Given this list of marker genes WRNIP1, SCAP, TST, CYB561, PCLO, SLC38A10, BEX2, CACNB3, NAAA, EML3, MAGI1, EFEMP1, ZC3HAV1, TVP23A, SLC25A4, SYT17, FBXW9, ANKRD13B, FUCA1, EPS8 (EGFR pathway substrate 8, signaling adaptor), DVL3, CD55, EXOSC4, SPR, TOM1L1, HSD17B14, DNAH14, KRT5 (NCBI Gene Id 3852), TM7SF3, AP5Z1, STRADB, PACRG, CHCHD6, DNALI1, CCDC85C, UBTD1, P4HTM, GRB7, ADARB1, SLC51A, MTHFR (NCBI Gene Id 4524), CAV2, STX11, IFT140, C1RL, SMOC2, TLL1, P4HA2, IGFBP2, FIG4, MTUS1, NOP16, HVCN1, FRAS1, NPDC1, C4B, P3H2, RALGDS, UBE3C, PAK4, TYRO3, HINT3, FXYD7, JOSD1, ITGA6, LTBP2, PDZD2, GATA6-AS1, FMO1, PDE7B, RBP7, TSPAN13, PLAAT4, PCOLCE2, ADAMTSL4, DECR2, SLC2A1, GAS6, LYST, NACC2, TNNI3 (troponin I3, cardiac type), SLC25A23, PTPRF, NPW, ERO1B, NAT8L, JMJD8, TSC1, DISP1, LRATD2, VPS18, SIRPA, PHLPP2, IL13RA1, ANK3, TMEM8B, ADIRF, CACNA2D3, TRADD, HSBP1L1, NSUN7, SLC7A7, IL10RB, NHERF4, NADSYN1, PROS1, TNIP2, CACNA1H, WWC2, CRLS1, RECK, THBD, SLC4A2, RASSF7 (Ras association domain family member 7), SRP19, CCDC106, CDK2AP2, OSTM1, ADAMTS8, ZNF503-AS2, PIM3, PSMB8, PLXNB1, VAMP8, CCDC51, GSDMD, TMEM151A, IFI35, SPEG, FLRT3, TMEM88, SPTLC2, ANXA3, IRAK1BP1, SPECC1, ZNF174, HSPA12A, PALS1, C11orf98, HOOK1, PDGFD, CRB2, COLGALT2, IL17RD, HRH2, NELL2, RHPN2, SPACA6, ITGB8, ITM2A, HEXB, HDAC7, PLA2G2A, CCDC112, TOLLIP, SYCE1L, EPS8L1, SLC16A4, UCHL1, DTD2, SPMIP5, LGALS2, COL2A1, METTL21A, CTIF (cap binding complex dependent translation initiation factor), TSPAN7, RNF207, ACKR3, SLC39A10, IL1R1, STK26, FABP3, UBXN2B, MKNK2, TGFB3, PAWR, ITGB5, THBS3, DPP4, SLC26A11, FAM50B, DOK4, PEG3, SNX8, FCGR2A, RTN4R, SGSH, ECHDC2, USP9X, AMOTL2, SLC16A1, WARS1, LRRC8A, SCPEP1, CCN4, LINC02381, TEAD4 (TEA domain transcription factor 4), EMP1, SEZ6L2, PYCARD, NBPF9, SINHCAF, SBSPON, TLCD4, DHCR24, TM4SF1, COL9A2 (collagen type IX alpha 2 chain), SGPL1, TFPI2, ITLN1, ABHD12B, PRKCI (protein kinase C iota), ZNF579, PDGFC, MYO1C, NBPF26, ABHD5, ZDHHC24, MID1, CDON, ALDH1A3, SLC25A29, INF2, TSPAN18, SH3GLB2, PGF, UNC5B-AS1, FGF13, CDC42EP3, BCAS4, PKHD1L1, GJA1, CFC1, COL26A1, DCTN6, BICDL1, SERPINB1, KLHL36, FGF18, NEO1, TNNI1, TNFAIP8L3, MUS81, ATP9A, NLRX1, CCDC74B, ERBIN (NCBI Gene Id 55914), SMAD3, PHYHD1, ARRDC1, MIF4GD, LLPH (NCBI Gene Id 84298), CTSH, INTS5, ACTC1, CGNL1, HHIP-AS1, HPGD, DYNLT2B, BTBD6, BMP3, UNC5B, MN1, MMEL1, ARL2, PRSS33 (NCBI Gene Id 260429), TAF10, LINC00842, BST1, LRRN4, ASPHD1, PKP2, BDNF, ARRDC4, TGM1, NDRG1, FRY, ADAMTS5, ZFPM2, EEIG1, PTPRQ, SMPD3, IGFBP6, PLEC, C3, ACOT7, TRNP1, SP1, ALCAM (NCBI Gene Id 214), GKAP1, NQO1, LINC01550, ROM1, TPD52, MTHFS, NGEF, PITPNC1, RHOD, FAM98A, ZNF219, WFDC1, CNTN3, SLC22A18, LPCAT3, EPHA3, ARMC9, STAU2, PEX11A, GSG1L, MGAT4B, SORBS2, NRBP2, ITPR3, MAP3K3, SIRT5, BCR, SH3BP5 (SH3 domain binding protein 5), TGFB2, ERRFI1, EPB42, MAILR, AAGAB, TBC1D22A, AGAP3, KLK8, FAAH, ABHD8, GLS, LGALS8, DIPK1A, TBX18, BTC, HEG1, FSTL3 (follistatin like 3), SYS1, STK24, EGLN2, CARNS1, PARP9, JUP, PODXL, PRELID2, NDUFA7, MRGPRF, PKIA, PTDSS2, DDR1, EPS8L2, MTHFD2L (methylenetetrahydrofolate dehydrogenase (NADP+ dependent) 2 like), ARPC1B, CITED4, REPIN1, GCLC, SEMA6A, SERGEF, PHYHIP, ANKRD50, ADAMTS3, FZD7, PLLP, TMEM176B, COL9A3, TRAF5, BEX1, REC8 (REC8 meiotic recombination protein), NUDT14, CTTNBP2NL, SETDB2, BICC1, B3GALNT1 (beta-1,3-N-acetylgalactosaminyltransferase 1 (Globoside blood group)), CDV3, CLIC3, SVIL, RGS5, NIPAL3, FKBP11, GRID2, RNF141, FAM174C, EDN3, MYCBP, CRABP2, HOXC5 (NCBI Gene Id 3222), NXPH2, TENM2 (teneurin transmembrane protein 2), DNAJC22, ASAP3, PTPRE, CADM2, PPP1R21, HHIP, KRT19, CCDC74A, PERP, HSPG2 (NCBI Gene Id 7796), RAP1GAP, ZMIZ1, NRG4, PGRMC2, NFATC2, NMU, PTPN14, ADAMTS9, COL8A1, MVP, ITPK1 (inositol-tetrakisphosphate 1-kinase), ASH2L, STIM2, ZMYM3, IL6R, NET1, INO80C, GALNT18, CADPS2, TCEA3, OTUD5, BCL3, GABARAPL1, SOX6, FLRT2, KHDRBS3, SSX2IP (NCBI Gene Id 22892), DAG1, CFI, DUSP2 (dual specificity phosphatase 2), TKFC, SLC38A1, GPR137B, TOMM34, LIMS2, LRRC32, SVIP, PYGL (glycogen phosphorylase L), CTXN1, MAMSTR, SMIM11, C21orf91, ABHD17A, ANXA8, RPRD1B, LINC00665, AGRN, SNAP47, TAOK2, RAB33A, ADAM17, EHD4, ATP11A (NCBI Gene Id 84170), EPCIP, CYTOR, CDK7, SYNGR2, PCDHAC2, CEP162, TOR1AIP2, OCIAD2, PLXNA2, PODN, SASH1, EFNB3, PLEKHA4, PNMA8A, TCEAL2, ARL8A, NOL4L, ETHE1, CLPTM1L, CDH3, ARHGAP22, AQP3, CDH2, MANSC1, AXL, PLAUR, ST6GAL1, WFDC2, KIF13A, AMPD2, TMUB1, ATF7IP2, SLC6A13, LPAR5, DHRS3, ANOS1, NDFIP2, ARSA, RSPO1, AMHR2, SLC29A3, GALNT9, MAP3K8, CERK, SLPI, HTR2B, CXADR, EPHA7, DLG2, DNAJB12, SLITRK4, MST1, PHC2, WT1, COL11A1, ANXA8L1, MLLT1, CLDN15, DSC2, FNDC1 (NCBI Gene Id 84624), LINC01018, CFC1B, RSPO3, RCHY1, FN3K, C1QTNF1, TNFRSF12A, SLC10A3, TTLL5, NPNT, COBLL1, CMYA5, TAP1, GLP2R, ITGA3, RAB7B, FOXP4, TDRP, RAB6B, GBP3, NMI, PDGFA, PLCB1, KRT8, TMCO3, TBC1D9, LRRTM1, LINC01133, TES, CCDC186, CRIM1, PPIL6, PSMB9, AGFG1, ZNF512B, PDXK, CALHM6, GSDME, STRBP, GADL1, FBN3, HACD1, ELFN1, FDXR, ARHGAP23, GRM7, SH2D4A, TCAIM, DPP3, NSG1, PHACTR1, OSMR (NCBI Gene Id 9180), TOB1, PLCE1, DOCK11, KRT17 (keratin 17), MINCR, MOK, NEDD4L, MET, ADAM33 (NCBI Gene Id 80382), NINJ1, CFB, UBE2Q1, CYP4B1, TOX, NHSL1, CA9, PPL, CFAP68, RERG, SMTNL2, FCHO1, KDELR3, OLFML2B, SLCO3A1, MCUB (mitochondrial calcium uniporter dominant negative subunit beta), RFK, CCPG1, EFNB2, RIC3, NHSL3, KIRREL1, NCOA7, OSCP1, CD47, LSR, LMO7, EGFLAM, ERAP2, CYSTM1, MT1E, NAV2, IQCA1 (NCBI Gene Id 79781), SH3BP4, ST6GAL2, CAMK1D, GBA1, DCBLD2, PRKAA2, FAM221A, CYB561D2, VPS13A, PYGM, TNNT2, ADH1C, GPC1, ADCK2, DPP7, COL18A1, IRF7, SEC11C, PLAAT3, LMNB1, SNCAIP, OBSL1, YDJC, CFH, SLK, ANKRD29, SMAD6, STAP2 (signal transducing adaptor family member 2), DHCR7, TPBG, ZDHHC12, SLC16A3, TCEAL5, ZFTA, SPACA9, HOXC4, SULF2, ENTPD6, ATP6V0E2, PLEKHA7, MYRF, COQ8B, TMEM9B, NBPF20, TUSC2, IQCJ-SCHIP1, L3MBTL3, ATP2C1, GCHFR, ENTPD2, SPRR2F, RAPGEF3, LRRC42, SLC48A1, MYO19, VWA5A, KANK1, KNDC1, CARD16, MAP3K11, IFT20, PDLIM4, B9D1, APLP1, NXN (NCBI Gene Id 64359), LGI2, GIT1, ARHGAP29, PXDC1, MSLN, LEPROTL1, LRRN1, B3GNT2, TNFSF13, AIF1L (NCBI Gene Id 83543), SPINT2, PROCR, RSPH3, PARM1, MCRIP2, GPRC5A, PTPN18, PDZRN4, FGFRL1, FAM20A, PPP1R16A, CPNE2, ATP7A, PCP4, PDGFRL, WASF1, SSH3, PDE4DIP, GNB5, SMPDL3B, SCARB1 (scavenger receptor class B member 1), CD320, RAC2, KCNIP1 (potassium voltage-gated channel interacting protein 1), DOK7 (docking protein 7), CNTN4, CA11, SHTN1, A1BG, CYB5R2, CLDN1, MEGF6, REEP1, ZNF524, PARD3B, PTGS1, CALML4, NSUN5, SCTR, CD74, CD22, UBXN6, PARD6B, TUBB2B, CAVIN2, SDSL, SLC7A4, ASPG, DUSP23, TMEM37, PNPLA4, PRXL2C, TMEM106C, RABGGTA, IGSF9, POM121, ALDH1A2, GCA, C1GALT1 (NCBI Gene Id 56913), DEDD2, MRPS17, CDK20, ANXA1, NLGN3, RNF227, C1R (NCBI Gene Id 791254), CTSD, WNT2B, STXBP2, MOGS, SEMA3C, GATA4, ERAP1, TMEM191C, EFNA1, AIF1, PDE1A, CCDC30, AGAP1, TNFAIP8, MYO5B, DOK5, CPZ, OPTN, RHOU (NCBI Gene Id 58480), BCO2, HTRA1, MEIS2, MYEF2, LAMA3, FGF9 (NCBI Gene Id 2254), PICK1, ADAM15, GOLGA8B, SERPINB9, KLF5, SPOCK2, TSTD1, NOMO2 (NCBI Gene Id 283820), A4GALT, MEDAG, DMKN, POMGNT2, MIB2, FBXL2, SFRP5, TBC1D17, B4GALNT4, FAM241A, SCAI (NCBI Gene Id 286205), ARVCF, CACHD1, VSIR, IFI27L1, TMEM176A, GLIS2, RAB11FIP2, NTNG1, C19orf33, CSDC2, COL8A2, PDPN, ASS1 (NCBI Gene Id 445), RNPEPL1, PTAFR, HMCES, FZD6, TNXB, FREM2, SIGIRR, CA2, SLC26A2, TLE4, DTD1, CAPG, DOCK9, COL4A6, SPRYD3, BAIAP2, RIN2, ATL1, C6orf62, SPATA33, SNHG19, DDX19B, AFDN, LRRC61 (leucine rich repeat containing 61), GFPT2, SDC4, PRKCZ, H2BC12, EDEM2, KLK5, AP1G2, CPLX1, MACROD2, PCK1, FLNB, NPR1, PTGIS, SLC35A2, XPO6, ZBTB7C, DHRS12, SBK2, UPK3B, SMIM1, SIRT7, KRT13, ABRACL, CYSLTR1, DHRS1, TMBIM4, RNASE1, WWC1, SP100, PSMG4, TMEM120B, KCNT2, ARNT2, DTX2, CCNDBP1, LAMA5, GEM, MAG, THSD4, COMTD1, CD9, ARL4A, CRIP1, USP53, PDZK1IP1, SLC34A2, KLK11, CRACR2B, SULF1, TM7SF2, NINL, NCOR2, SFTPD, AQP1, ADGRB2, RPS6KA2, AFF1, LTC4S, FAM110C, FAM234A, CYBC1, CLCF1, ZNF467, SPRYD4, MBP, CASP4, SEMA4B, SRSF8, C4A, ZNHIT2, ZNF629, NPEPL1, PLEKHA1, CMTM8, NRXN2, APOL2, HACD4, RAB11FIP1, BCAR3, GPM6A, SEMA3B, FLNC, SEC14L1, AHDC1, RNASE4 (NCBI Gene Id 6038), KLF2, PLP2, FENDRR, KLF13, KRT18, ITSN2, TMEM132A, CALML3, EPCAM, LY6H, PTHLH, PAMR1, DBNDD2, RGS10, BNC1, CLSTN3 (NCBI Gene Id 9746), PAPPA, ABCC1, SMIM27, APBB2, ALOX15 (NCBI Gene Id 246), CGN, SLX1A, CCND3, BOK, DSG2, MIEN1, KRCC1, SCG5, BNC2, CLUL1, HAGH, SLC30A6, HSPB8, ARF3, KLK10, TNNT1 (troponin T1, slow skeletal type), ZNF641, MMP28, HDDC3, CXXC5, C14orf132, PRR5, LAMC2, NCAM2, RDH10, here is a description of the gene set: Mid mesothelial studied in species Homo sapiens from publication He P, Lim K, Sun D, Pett JP, Jeng Q, Polanski K, Dong Z, Bolt L, Richardson L, Mamanova L, Dabrowska M, Wilbrey-Clark A, Madissoon E, Tuong ZK, Dann E, Suo C, Goh I, Yoshida M, Nikolić MZ, Janes SM, He X, Barker RA, Teichmann SA, Marioni JC, Meyer KB, Rawlins EL (PMID 36493756) Human Gene Set: HE_LIM_SUN_FETAL_LUNG_C0_MID_MESOTHELIAL_CELL